The following is a description of a gene set: Genes having at least one occurence of the motif ACATATC in their 3' untranslated region. The motif represents putative target (that is, seed match) of human mature miRNA hsa-miR-190 (v7.1 miRBase). species: Homo sapiens Human Gene Set: ACATATC_MIR190, and this is the list of marker genes: STK35, YTHDF3, NLGN1, NFASC, BCL11A, SMC6, CLOCK, RLIM, ARF4, SRSF1, STK24, TNRC6B, TNRC6A (trinucleotide repeat containing adaptor 6A), OTUD4, PAPOLG (poly(A) polymerase gamma), ZIC3, MYO5A, ANO4, TCF4, PHF20L1, HERC4, WSB1, MFSD14B, SYNJ1, TRPS1, ACTR3, STC1, DAG1, ASAP1, RBAK, PAX6, PTHLH, ARPC5, BACH2, TSHZ1, WDR44, KCNQ5, NAV3, FOXP2, HAS2, EPC2, HECA, RPS6KA3, SAMD4A, SLITRK1, CELF4, WDFY3, NEUROD1, CHD7, TRIM36, PHLPP1, HGF, TP53INP1, PCDH9, MEX3B, GPHN, DMD, CADM1, TBC1D14, CDKN1B